The following is a description of a gene set: studied in species Mus musculus from publication Chen Y, Wang X (PMID 31504780) Genes predicted to be targets of miRBase v22 microRNA mmu_miR_3082_5p in miRDB v6.0 with MirTarget v4 prediction scores > 80 (high confidence targets). Mouse Gene Set: MIR_3082_5P, and this is the list of marker genes: Gosr1, Dlg1, Mrps17, Meox2 (mesenchyme homeobox 2), Pskh1, Cpne3, Ddr2, Fam133b, Serinc5 (serine incorporator 5), Gsk3b, Tshz3, Asb3, Bach2, Cpeb2, Map2, Gsap, Hpgd, Mgat3, Pakap, Ndufb5, Hic1, Rybp, Tmc3, Cytip, Flrt2, Xpc, Macir, Vsig1, Gtf3c2, Adora3, Ammecr1l, Ift74, Glod4, Apbb3, Cacna1d, Pabir2, Chic1, Arpp19, Adamts13, Syn3, Sgcd, Thnsl2 (NCBI Gene Id 232078), Akap5, Homer2, Ago4, Robo2, Thg1l, Ipo9, Nvl, Dusp6, Itgb3bp, Hoxc6, Slco3a1, Sorbs2, Iqsec2, Kat6a, Entpd7, Ccdc127, Pank1, Stap1, Alx1, Ppp1r16b, Nfia, Glrb, Alg9, Kif5a, Thy1, Ces2c, Anxa1, Chn2 (chimerin 2), Plagl1, Rexo1, Zfp12, Bcor, Rtn1, Zfp423, Arl5a, Cdkn1b, Bnc2, Pik3ca (phosphatidylinositol-4,5-bisphosphate 3-kinase catalytic subunit alpha), Tmcc3, Kctd1, Rnmt, Tpm4, Erg, Set, Taf2, Rnf115, Mapk8ip3, Cln3, 4930519G04Rik, Rnf2, Septin11, Dcx (NCBI Gene Id 13193), Fbrsl1, Pag1, Reep3, Elmo2, Trappc4 (NCBI Gene Id 80545), Ubn2, Srek1ip1, Clxn, Zhx1, Cltrn, Adgrv1, Nras, Ktn1, Tmprss12, Nr4a3, Incenp, Zmiz1, Scn1a, Lrp4, Srsf7, Ric3, Tdrd3, Exph5, Tspan3